Given this list of marker genes SLC4A1, CA1, CYB5R4, CA4, CYB5R2, CA2, CYB5RL, HBB, HBA2 (NCBI Gene Id 3040), AQP1, CYB5R1, RHAG, HBA1, here is a description of the gene set: Human Gene Set: REACTOME_ERYTHROCYTES_TAKE_UP_CARBON_DIOXIDE_AND_RELEASE_OXYGEN species: Homo sapiens Erythrocytes take up carbon dioxide and release oxygen